The following is a description of a gene set: Human Gene Set: GOBP_INTERLEUKIN_1_PRODUCTION species: Homo sapiens The appearance of interleukin-1 due to biosynthesis or secretion following a cellular stimulus, resulting in an increase in its intracellular or extracellular levels., and this is the list of marker genes: TMEM106A, ANXA1, MIR766, CASP1, IL6, MIR204, LILRA5, PYDC1, LPL (NCBI Gene Id 4023), EGR1, NLRC4, S100A13, AZU1, FZD5, GBP5, ZC3H12A, TYROBP, CX3CL1, ACP5 (acid phosphatase 5, tartrate resistant), CD33, NLRP1, IL16, MIR181D, ISL1, MALT1, USP50, TRIM16, TNFAIP3, TLR6, TREM2, PYDC2, PANX1, MYD88, APOA1, WNT5A, CASP8, FFAR4, S1PR3, FOXP1, ARG2, CALCA (calcitonin related polypeptide alpha), MIR98, SPHK1, NLRP3, ARRB2, LILRA2, MIR708, ORM1, APP, RAD21, GSDMD, GAS6, LGALS9, SAA1, PANX3, GSTP1, GIT1, IL1R2, ELF4, NOD2 (nucleotide binding oligomerization domain containing 2), HDAC3, IGHD, CEACAM1, AGER, IFI16, LILRB4, MEFV, HK1, NLRP2B, P2RX7, SERPINB1, IGF1 (NCBI Gene Id 3479), MIR488, MIR877, IL17A, MIR920, CD36, MIR361, NLRP7 (NCBI Gene Id 50956), PML, F2RL1, MIR195, CARD8, MIR132, CCL3, F2R, HAVCR2, JAK2 (NCBI Gene Id 3717), MIR181C, TNF, CCR7, ERRFI1, CLEC7A, MIR144, RIPK2, PYCARD, MIR101-1, NLRP12, HDAC2, NAIP, MIR181A2, MIR206, ORM2, RELA, STAT3, CARD16 (NCBI Gene Id 114769), MIR27B, CARD18, TLR4, IL10, FFAR1, STMP1, CCL19, SMAD3, CX3CR1, MIR142, INAVA, CPTP, GHSR, GHRL, AIM2, TMED10, NLRP2, SIRPA, NR1H4, NOD1, CARD17P, HSPB1, TLR8, HMGB1, IFNG, PANX2, NLRP10